Given this list of marker genes Ddx3x, Golph3, Neurog1, Fbn2, Srpk2, Fam90a1a, Gtf2h1, Satb1, Lpcat2b, Zfp697, Hcn3, Rnf152, Spty2d1, Fam98a, 4833439L19Rik, Kdm2b, Tet2, Rps27l (NCBI Gene Id 67941), Il17a, Klhl13, Luc7l2, Mpp4, Map7d2, Ppargc1a, Ino80d, Kctd4, Nfib, Smurf2, Mbd3l2, Eri2, Wipf1, Lrrc28 (NCBI Gene Id 70388), Tnrc6a, Gabra1, Rbms3, Rgs7bp, here is a description of the gene set: studied in species Mus musculus Genes predicted to be targets of miRBase v22 microRNA mmu_miR_1929_3p in miRDB v6.0 with MirTarget v4 prediction scores > 80 (high confidence targets). Mouse Gene Set: MIR_1929_3P from publication Chen Y, Wang X (PMID 31504780)